Given this list of marker genes PLD4, SBF1, MYADM, GATD3, DPM2, PIP4P1, FHOD1, EIF3K, SOBP, S100A5, SCMH1, MGAT5, GET3, ITGAX, KHDRBS3, POLDIP3, CENPM, PHPT1, TPM3, GUCA1A, SCARF1, NME1, CCDC81, MAP1A, TBC1D1, RASGRP3, MAD2L2, DCP1A, SEPTIN6, ATP2A3, FXYD2, AMH, SLC1A1, TNFAIP8L1, HMGN3, NPDC1, UBTD1, TACSTD2, RUNX3, ZNF562, CCDC51, IMPDH2, MIA, SLC25A15, ZNF29P, TNF (NCBI Gene Id 7124), SYT5, GPR68, RAB3GAP1, POGLUT1, PON2, IGFBP6, KIAA1671, DHRS12, BCL7C, NRIP3, KPNB1, RBMS2, KIF17 (NCBI Gene Id 57576), HYAL2, SCRT1, NKIRAS2, GANC, XYLT1, SLC3A2, TRIP10, GDI2, GFOD3P, LINC01405, TMEM262, GDI1, H1-3, TNIP1, MMP12, UQCRB (NCBI Gene Id 7381), RNF41, ACTR3B, PPP1R14A, ISYNA1, HBM (hemoglobin subunit mu), FSCN1, TREML2, RANBP10, PXDC1, TEX28, SLC25A2, OGFRP1, CPA5, MOB3A, CDKN1A, NUDT5, TSPAN15, INPP5D, ECHS1, OR7E36P, ARHGEF2, ILRUN, COMTD1, STK32C, UQCR10, BAZ1B, RC3H2, SND1, GGA1, GPAT3, TRPM4, TMEM38A, PIP5K1C, SRARP, PRPS1, ZNF764, ADGRB1, PCSK7, ADAMTS8, SERPINF2, ABHD2, AOPEP, GGTLC1, FAM20A, DUSP2, YARS1, CTAGE9, PMAIP1, MEGF8, CAMKK2, MPIG6B, STARD7 (NCBI Gene Id 56910), CD1B, RCN3, ABCF2 (ATP binding cassette subfamily F member 2), ZBTB43, CHCHD4, VDAC2, RAP1GAP, INTS3, PEA15, PHLPP1, RSPRY1, MC4R (melanocortin 4 receptor), TGIF2, PRRC2A, PDLIM7, ENTPD1, NDUFA12, KIAA0040, SLC7A11, MT1E, IL22RA2, BAP1, CHD3, SHCBP1, NARS1, PPP5C, ATP5F1B, TOMM34, PRSS50, HELZ2, LINC01106, LOXHD1, NLRC5, MTCL2, ABCB4, TENT4B, NBPF3, MAD1L1, AGPAT1, GRAMD1A, GALM (NCBI Gene Id 2718), FA2H, SLX4IP, GRIPAP1, PSMB3, RFTN1, OLA1, LRP8, ZEB1-AS1, TUBA4A, SLA, BTLA, F3 (NCBI Gene Id 99486), ZNF641 (NCBI Gene Id 121274), TLR6, VWA5B1, TESK1, CHMP4B, PSKH1, NAGPA, CAPNS1, MATK, ADGRB3, PHB2 (prohibitin 2), LTO1, ZNF48, CDC42EP5, CHST13, IFNGR2, AGFG2 (ArfGAP with FG repeats 2), PRSS3, PGM2, here is a description of the gene set: T cell anergy is one of the mechanisms contributing to peripheral tolerance, particularly in the context of progressively growing tumors and in tolerogenic treatments promoting allograft acceptance. We recently reported that early growth response gene 2 (Egr2) is a critical transcription factor for the induction of anergy in vitro and in vivo, which was identified based on its ability to regulate the expression of inhibitory signaling molecules diacylglycerol kinase (DGK)-a and -z. We reasoned that other transcriptional targets of Egr2 might encode additional factors important for T cell anergy and immune regulation. Thus, we conducted two sets of genome-wide screens: gene expression profiling of wild type versus Egr2-deleted T cells treated under anergizing conditions, and a ChIP-Seq analysis to identify genes that bind Egr2 in anergic cells. Merging of these data sets revealed 49 targets that are directly regulated by Egr2. Among these are inhibitory signaling molecules previously reported to contribute to T cell anergy, but unexpectedly, also cell surface molecules and secreted factors, including lymphocyte-activation gene 3 (Lag3), Class-I-MHC-restricted T cell associated molecule (Crtam), Semaphorin 7A (Sema7A), and chemokine CCL1. These observations suggest that anergic T cells might not simply be functionally inert, and may have additional functional properties oriented towards other cellular components of the immune system. from publication Zheng Y, Zha Y, Spaapen RM, Mathew R, Barr K, Bendelac A, Gajewski TF (PMID 23548837) studied in species Homo sapiens Genes up-regulated in CD4 Th1 cells: wildtype versus EGR2 knockout. Human Gene Set: GSE46242_CTRL_VS_EGR2_DELETED_TH1_CD4_TCELL_UP